Given this list of marker genes MOG, GRM2, IL1RAPL1, GPR162, CELA2A, SUPT4H1, RAB26, FBLN5, DYM, ST7L, SMARCD2, EEF1AKMT1, C8orf48, SSC5D, CCN1, LHX6, HCN1, ATF1, SEC23IP, OXSR1, GSX1, GPI, COL9A1 (collagen type IX alpha 1 chain), BCL10, RTN4 (reticulon 4), NUCB2, VSTM2B, SRRM1, MDGA1, EIF3F, TRIM17, KCTD15, PHYHIPL, NAP1L1, TEX14, RPRD1A, H19, CCDC191, KIF13A, CHRNB3, RBMX2, AAMDC, SULT4A1, AMPH, RAB7A, NLRP4, HBZ, SPOCK1, MTMR12, FOXA2, SPMIP4, DPY19L1, MISFA, MAP7D2, NCOR1, TMEM225, TCF21, WNT2B, DGKG, SERPINA4, GRHL2, LIN7A, DPH1, SLC7A4, PPME1 (protein phosphatase methylesterase 1), RIDA, ST8SIA3 (ST8 alpha-N-acetyl-neuraminide alpha-2,8-sialyltransferase 3), AGTRAP, TMPO, AKR7A2, ZBTB1, KAZN, ERC2, CSNK1A1, C9orf78, GRIK4, NAV3, FABP2, SLC5A4, DNAJB13, DLK2, TBX15, SH3RF3 (NCBI Gene Id 344558), LARGE1, GPX7 (glutathione peroxidase 7), EFL1, TTC12, GPR101, FBH1, KRT6A, MTSS2, TNMD, GABARAPL1, TMEM218, COL6A2, XPO4, FSCN3, STARD10, EPM2AIP1, GABRA4 (NCBI Gene Id 2557), RPAP2, BTBD3, CD300LG, CDKL3, BMP8B, PCLO (piccolo presynaptic cytomatrix protein), FBXO15, RBM39, SPIN4, CDKL4, SH3RF1, HIBADH, ADRA2A, RBM24, NINJ1, MEX3C, FGF9, GCNT7, TRIM34, DCXR, FNDC3B, ARL13A, SDHA (NCBI Gene Id 6389), ETV4, STAM2, SQOR, UGT2B17, ANXA13, DES, IGFALS, ACOX1, STARD13, VEPH1, EEF1B2, MADCAM1, MAP2K1, RIMS3, CD248, SFR1, TFAP2C, HAO1, GABRR1, ZNF428, NHERF2, B3GAT1 (beta-1,3-glucuronyltransferase 1), HRH4, AQP5, HSD17B3, SMPD3, GPR37L1, RPL12, RS1, GNG13 (G protein subunit gamma 13), TRPM3, ACCSL, NCALD, OAZ1, SLC25A51, MID1IP1, PTRH1, CASR, MAGED1, PIK3CG, SLC35F1, EHF, CD109, PRR13, VAMP4, ZNF217, ARHGEF3, MS4A10, NICN1, CCT7, EMC2, PDE4A, MYO5C (myosin VC), ZNF516, ADGRL2, MFGE8, SLC5A3, MTCL1, ELMOD3, SPHKAP, MITF, LTBP1, COL24A1, XIRP1, WNT6, CHD5, GRIN1, THAP11, TRPM4, TMEM150A, CFAP119, NEU2, COPZ2, VAV3, GLYAT, PAX1, FBN1, here is a description of the gene set: Genes down-regualted in comparison of regulatory T cell (Treg) from CBFB deficient mice versus those from wild type animals. Gene expression profiles of Cbfb-deficient and control Treg cells were compared. Naturally arising regulatory T (Treg) cells express the transcription factor FoxP3, which critically controls the development and function of Treg cells. FoxP3 interacts with from publication Kitoh A, Ono M, Naoe Y, Ohkura N, Yamaguchi T, Yaguchi H, Kitabayashi I, Tsukada T, Nomura T, Miyachi Y, Taniuchi I, Sakaguchi S (PMID 19800266) studied in species Homo sapiens Human Gene Set: GSE18148_CBFB_KO_VS_WT_TREG_DN